Given this list of marker genes SKAP2, SNX18, PDK1, MTFR1, C11orf65, AKT1, VMA21 (NCBI Gene Id 4202), TALDO1, PHKG2, NAIP, STN1, EMC10, ZWINT, PIK3CA, SCAND1, ARHGEF9, CAD, CREB5, TRMT1, ARV1, OGFOD3, PIGH, KAT2B, UBA5, TCHP, AIFM1, ATP5PF, DENND6A, TP53RK, DDX39B, BAG5, MRPL3, BRIX1, MAPKAPK3, SLC38A6, TTLL5, LSM12, CUTA, TCEA2, C1orf53, SFXN4, TXK, PLCL2, RCN2, EVL, ZNF195, EGR2, LOXL3, RSL1D1, CNPY3 (NCBI Gene Id 10695), NDC1, EIF3LP3, TFAM (transcription factor A, mitochondrial), TOR2A, PTGS1, CAMK2G, ZNF367, PSMG4, UGP2 (NCBI Gene Id 7360), RRS1, DNAJB1, MAML3, EFCAB2, TMEM9B, ELP4 (elongator acetyltransferase complex subunit 4), DAGLB, POLR2L, NIBAN2, ING4 (NCBI Gene Id 51147), GPX1, COG2, TSHZ3, ANAPC10, MAP7, HMGN5, ANKRD35 (NCBI Gene Id 148741), MCM6, HNRNPDL, C10orf143, BIN3, MIPEP, DERA, NDST1, SP2-AS1, AP1M1, OXNAD1, TMEM243, PREP, CTBP2, TEX264, SKA2, KLHDC3, THBD, S100A6, MRPL24, KDM7A, PMPCA, RHBDD2 (rhomboid domain containing 2), PAK1, SOWAHC, N4BP2, KCTD5 (potassium channel tetramerization domain containing 5), PLXND1, PAICS, UROS, DPM1, EIF2D, UQCRH, TACC3, SLC39A10, MSRA, TXNDC17, RPS26, AP2M1, GPR34, UTP11, CTH, EFTUD2, CCT6B, SRA1, COQ6, POLE4, DDIAS, ZNHIT1, DMAC1 (distal membrane arm assembly component 1), NDUFA2, IMPA2, SLC39A3, WDR1, TPST2, ARMCX5 (armadillo repeat containing X-linked 5, NCBI Gene Id 64860), PSTPIP1, CENPQ (NCBI Gene Id 55166), BBS4, PTAFR, WIPF2, TMCO1, WDR46, RPS6KA3, MRPS24, EHMT1, ID1, CHMP3, TOR1AIP1, CRYZL1 (crystallin zeta like 1), RLIM, ALDH5A1, ATP6V0D1, TRIAP1, TRMT10C, CHN2, TMEM183A, ATR, GDPD1, CIAO2B (cytosolic iron-sulfur assembly component 2B), TMEM160, SRSF6, RPS6KB1, TRAM2, TOMM70, CEP152, IMPACT, PLEKHH1, UQCRQ, SYAP1, TFDP2, C9orf78, DRG1, METTL25B, RPAP2, MFAP3, SRM, MSH3, SNRPD1, TRAPPC14, EIF2A, ZNF813, GPR82, MBOAT1, PIK3C2A, BTBD3, COQ9, NPTN, PACSIN2, BANF1, UHRF1, LINC00667, FRMD4B, PSD4, CRTAP, TRAPPC12, SMC5, NOL10, TSPAN32, SLC35D1, CCP110 (NCBI Gene Id 9738), CLCN3, PRMT2, NDUFAF5, here is a description of the gene set: Human Gene Set: GSE40666_UNTREATED_VS_IFNA_STIM_CD8_TCELL_90MIN_DN from publication Gil MP, Ploquin MJ, Watford WT, Lee SH, Kim K, Wang X, Kanno Y, O'Shea JJ, Biron CA (PMID 22968462) Type 1 IFNs can conditionally activate all of the signal transducers and activators of transcription molecules (STATs), including STAT4. The best-characterized signaling pathways use STAT1, however, and type 1 IFN inhibition of cell proliferation is STAT1 dependent. We report that type 1 IFNs can basally stimulate STAT1- and STAT4- dependent effects in CD8 T cells, but that CD8 T cells responding to infections of mice with lymphocytic choriomenigitis virus have elevated STAT4 and lower STAT1 expression with significant consequences for modifying the effects of type 1 IFN exposure. The phenotype was associated with preferential type 1 IFN activation of STAT4 as compared to STAT1. Stimulation through the TCR induced elevated STAT4 expression, and STAT4 was required for peak expansion of antigen-specific CD8 T cells, low STAT1 levels, and resistance to type 1 IFN-mediated inhibition of proliferation. Thus, a mechanism is discovered for regulating the consequences of type 1 IFN exposure in CD8 T cells, with STAT4 acting as a key molecule in driving optimal antigen-specific responses and overcoming STAT1-dependent inhibition of proliferation. studied in species Homo sapiens Genes down-regulated in CD8 T cells: untreated versus interferon alpha.